The following is a description of a gene set: The initial attachment of an autophagosome membrane to a target membrane, mediated by proteins protruding from the membrane of the vesicle and the target membrane. Docking requires only that the two membranes come close enough for these proteins to interact and adhere. studied in species Mus musculus Mouse Gene Set: GOBP_AUTOPHAGOSOME_MEMBRANE_DOCKING, and this is the list of marker genes: Stx17, Atg14, Atp2a2, Calm2, Calm3, Calm1, Vmp1, Snap29